The following is a description of a gene set: Combining with vasopressin to initiate a change in cell activity. Human Gene Set: GOMF_VASOPRESSIN_RECEPTOR_ACTIVITY species: Homo sapiens, and this is the list of marker genes: INPP5K, OXTR, NLRP6, AVPR2, AVPR1A (arginine vasopressin receptor 1A), NPSR1, AVPR1B